Given this list of marker genes FEM1C, TMEM184B, ALPK2, ELOA, MLX, PTPN3, FETUB, PCSK2, SSH2, MAST4, SLC45A4, SACM1L, RCAN2, DNAJC21, STK32C, BMPR2, GORASP2, GRSF1, NUDT4, BTG2, USP37, HACE1, IHO1, SLC25A12, SLC22A7, BTD, MFSD4B, CFHR3, KPNA6, DCUN1D4, GPATCH2L, SMC2, STK32A, CHST11, FZD3, OPRM1, RNF32, PLEKHA1, MSL2, AKT3 (NCBI Gene Id 26068), CDNF, MTFR1L, PALS2, CFHR4, KCNK9, USP1, LPAR5, MSL1, ETS1, ICE2, CEP89, ZC3H4, RCC2, UNC13A, SETD7, CHP2, ABCG1, PTCD2, NNAT, GGT7, TRIM33, COG6, DCX, RIMBP2, KERA, UGCG, KISS1R, ZNF461, DLEU7 (NCBI Gene Id 220107), CYP1A1, VPS50, GLYATL2, URI1, EIF3A, OLFML2B, YWHAE, SEPHS2, TMX4, SS18, CFAP47, NTRK2, CDO1, RNF139, HDAC9, APP, RSPH4A, ZNF326, CENPM, GRPEL2, MEX3C, KCNH4, TTPAL, TK2, here is a description of the gene set: from publication Chen Y, Wang X (PMID 31504780) Human Gene Set: MIR4786_5P species: Homo sapiens Genes predicted to be targets of miRBase v22 microRNA hsa-miR-4786-5p in miRDB v6.0 with MirTarget v4 prediction scores > 80 (high confidence targets).